The following is a description of a gene set: Any process that results in a change in state or activity of a cell or an organism (in terms of movement, secretion, enzyme production, gene expression, etc.) as a result of an interleukin-6 stimulus. studied in species Mus musculus Mouse Gene Set: GOBP_RESPONSE_TO_INTERLEUKIN_6, and this is the list of marker genes: Myb, Pck1, Jak1, Il6st, Camp, Spi1, C1qtnf4, Phb1, Gab1, Ctr9, Cebpa, Ripk1, Mir21a, Gfi1, Rela, Il6, Ptpn2, Sbno2, Cited1, Stat3, Traf7, Yap1, Src, Fer, Mir155 (microRNA 155), Ccl2, Stat4 (NCBI Gene Id 20849), Il6ra, Entpd2, Tut4, Foxa2, Ptprt, Selp, Cfl1, Smad4, Chi3l1, Nfkb1, St18, Pid1, Ptgis, Fgf23, St3gal6